The following is a description of a gene set: Abnormal circulating apolipoprotein concentration Human Gene Set: HP_ABNORMAL_CIRCULATING_APOLIPOPROTEIN_CONCENTRATION studied in species Homo sapiens A deviation from the normal concentration in blood of an apolipoprotein, i.e., of a protein that binds lipids to form lipoprotein and is thereby responsible for the transport of lipids in the blood and lymph circulation., and this is the list of marker genes: ABCA1, LPL, ATP6V1A, CCT5, ATP6V1E1, APOA1 (NCBI Gene Id 335), ATP6V0A2, APOC2, MTTP